The following is a description of a gene set: species: Mus musculus Mouse Gene Set: GOMF_SODIUM_ION_TRANSMEMBRANE_TRANSPORTER_ACTIVITY Enables the transfer of sodium ions (Na+) from one side of a membrane to the other., and this is the list of marker genes: Slc10a4-ps, Slc23a2, Slc5a5, Agt, Slc10a5, Slc18a2, Atp1a3, Slc10a1, Slc34a1, Glrx, Tmprss3, Slc6a13, Atp1b2, Hcn4, Slc29a1, Slc24a2, Scn10a, Slc41a3 (solute carrier family 41, member 3), Slc5a3, Grik2, Slc38a2, Slc5a4b, Scnn1g, Nalcn, Slc17a8, Slc17a6, Slc5a1, Slc6a5 (NCBI Gene Id 233238), Fxyd2 (FXYD domain-containing ion transport regulator 2), Slc4a9, Prss8, Slc9a8, Slc1a3, Slc8a1, Gm5134, Nedd4l, Slc6a1, Slc6a4, Slc9b2, Ptpn3, Mcoln3 (NCBI Gene Id 22316), Slc8a2, Scn2b, Cnga3, Scn8a, Fxyd5, Slc20a2, Cacna1g, Slc24a3, Pcsk9, Slc6a12, Slc38a3, Fgf13, Cacna1i, Trpm2, Prss30, Cav3, Atp2b4, Kcnk9, Grik4, Slc38a5, Slc8a3, Scn3b, Slc13a4, Tpcn1, Fxyd6, Slc9a3, Mfsd2a, Scn1b, Slc13a3, Scn9a, Slc41a1, Slc5a4a, Grin1, Cnga1, Slc5a8, Slc6a15, Slc1a7, Slc4a10, Trpm5, Slc1a1, Scnn1b, Slc5a6, Slc12a3, Mcoln1, Kcnk1, Fxyd3, Slc6a18, Fxyd7 (NCBI Gene Id 68670), Atp1a4, Slc28a3, Scn1a, Slc5a12, Asic4, Slc4a8, Scn2a, Atp1b1, Slc1a2, Hcn1, Slc13a5, Gpld1, Slc5a2, Trpv3, Slc34a3, Slc9c1, Slc18a1, Slc6a6, Kcnk3, Slc9a1, Slc22a3, Slc5a10, Slc6a3, Slc6a7, Slc9a2, Scn4a, Slc1a6, Slc5a7, Slc9a6, Atp1a2 (NCBI Gene Id 98660), Slc28a1, Slc10a4, Slc4a7, Slc6a11, Tpcn2, Scn5a, Slc23a1, Nos1, Slc12a1, Slc38a7, Slc38a4, Gria2, Nedd4, Slc4a11, Scn3a, Scn7a, Slc5a11 (solute carrier family 5 (sodium/glucose cotransporter), member 11), Asic3, Scnn1a, Slc34a2, Slc6a20b, Cnnm4, Slc20a1, Slc8b1, Tmem168, Sclt1, Snta1, P2rx7, Slc5a9, Slc10a3, Pkd2l1, Asic1, Slc6a9, Slc10a6 (solute carrier family 10 (sodium/bile acid cotransporter family), member 6), Slc28a2, Cacna1h, Commd1, Fgf12, Hcn2, Slc22a1, Slc6a8, Asic5, Slc4a4, Gpd1l, Slc13a1, Camk2d, Fgf11, Slc9a5, Pkd2, Slc6a14, Atp1a1, Cpox, Chp1, Slc24a4, Slc24a5, Slc10a2, Atp4a, Slc4a5, Fxyd4, Slc12a2, Scn4b, Hcn3 (hyperpolarization-activated, cyclic nucleotide-gated K+ 3), Slc6a20a, Slc22a5, Slc38a1, Atp1b3, Slc13a2, Slc24a1, Slc9a4, Grik3, Ywhah, Grik1, Grik5, Slc6a2, Asic2, Rangrf, Fgf14, Slc9a7, Scn11a, Slc17a7, Slc28a2b, Slc9a9, Atp12a, Fxyd1